Given this list of marker genes VCAM1, LYPD2, RBP5 (NCBI Gene Id 83758), ALCAM, CHODL (NCBI Gene Id 84535), HMCN1, MYOF, HAS2 (NCBI Gene Id 3037), CD82, FILIP1L, DUSP23, LTBP3, TLL1, MGP (NCBI Gene Id 4256), LFNG, S1PR4, SORBS2, RARRES1, ADAMTS6, SLCO2A1, DHH, XAF1, SELP, ACKR1, WFDC1, COL9A3, ASS1, SEMA3F (NCBI Gene Id 7868), ACKR3, HSPA2, ASAP3, APOL1, PLXDC2, SULT1E1, SERPINE2, ITGB4, CCDC69, COL3A1, PLAC9, EVA1C, ECRG4, EHBP1L1, PALLD, DNM3, FAM124A, SPINK5, NUAK1, VEGFC, PTGIS, LTC4S (leukotriene C4 synthase), TMEM273, PTGDS, CDH11, MIR503HG (NCBI Gene Id 84848), MAP2, HMGCLL1, CPE, CDC42EP3 (NCBI Gene Id 10602), HLA-DRB1, SCUBE3, IL1R1, TSLP, GFOD1, ASRGL1, LRATD2, PLVAP, CYP1B1, DLL1, IL11RA, C7, FBLN2, HDAC9, FBN1, ADGRG6, NALF1, MMP28, MIR99AHG, SRGN, MALL (mal, T cell differentiation protein like), SYT15, LHX6, ENTPD1, LYST, ATP2A3, NPNT, here is a description of the gene set: Venous endo Human Gene Set: HE_LIM_SUN_FETAL_LUNG_C3_VENOUS_ENDOTHELIAL_CELL from publication He P, Lim K, Sun D, Pett JP, Jeng Q, Polanski K, Dong Z, Bolt L, Richardson L, Mamanova L, Dabrowska M, Wilbrey-Clark A, Madissoon E, Tuong ZK, Dann E, Suo C, Goh I, Yoshida M, Nikolić MZ, Janes SM, He X, Barker RA, Teichmann SA, Marioni JC, Meyer KB, Rawlins EL (PMID 36493756) studied in species Homo sapiens